Given this list of marker genes RHOB, RTKN, RHOC, TAX1BP3, RHPN2, RHOA, RHPN1, ROPN1, LIN7B, here is a description of the gene set: part of: RHO GTPase Effectors Reactome Pathway: RHO GTPases Activate Rhotekin and Rhophilins Rhotekin (RTKN) is a protein with an N-terminally located RHO GTPase binding domain, that shares a limited sequence homology with PKNs and rhophilins. RTKN binds to GTP-bound RHOA, RHOB and RHOC and can inhibit their GTPase activity, which can be corroborated by protein kinase D-mediated phosphorylation of RTKN. RTKN is implicated in the establishment of cell polarity, septin organization and stimulation of SRF-mediated transcription. RTKN can have an anti-apoptotic effect that depends on the activation of NFKB (NF-kappaB). RTKN2 (rhotekin-2) is another rhotekin exclusively expressed in lymphocytes. The function and the mechanism of action of RTKN2 are unknown.<p>Rhophillins include two family members - rhophilin-1 (RHNP1) and rhophilin-2 (RHPN2) with ~75% sequence identity. A RHO GTPase binding domain is located at the N-terminus of rhophilins, followed by a BRO1 domain (characteristic of proteins involved in protein kinase C signaling) and a C-terminal PDZ domain. RHOA:GTP binds both RHPN1 and RHPN2 and these interactions may be involved in organization of the actin cytoskeleton and/or cell motility. RHOB:GTP recruits RHPN2 to endosomes which may be involved in the function of thyroid cells. species: Homo sapiens